The following is a description of a gene set: Human Gene Set: GOMF_7S_RNA_BINDING Binding to a 7S RNA, the RNA component of the signal recognition particle (SRP). studied in species Homo sapiens, and this is the list of marker genes: SRP54, SRP19, SRP14, SRP68, SRP9, EXOSC2, SRP72